The following is a description of a gene set: Genes up-regulated in CD4 T cells over-expressing FOXP3 and PPARg1 isoform of PPARG: GW1929 versus pioglitazone. studied in species Homo sapiens Pioglitazone treatment of CD4+FoxP3- T cells transduced with Pparg and Foxp3 up-regulated a set of genes whose products have been implicated in lipid metabolism pathways. To verify the specificity of this treatment, we performed microarray analysis on Foxp3+Pparg1-transduced CD4+FoxP3- T cells after treatment with other PPARg agonists such as Rosiglitazone (TZD) and GW1929 (non-TZD). Human Gene Set: GSE37534_GW1929_VS_PIOGLITAZONE_TREATED_CD4_TCELL_PPARG1_FOXP3_TRANSDUCED_UP from publication Cipolletta D, Feuerer M, Li A, Kamei N, Lee J, Shoelson SE, Benoist C, Mathis D (PMID 22722857), and this is the list of marker genes: OASL, RSAD2, COL4A1 (collagen type IV alpha 1 chain), SMR3A, FAM111A, TENT4A, TMEM106C, SFI1, IFITM1, AHSA1, ISG15, ZNF205, CAPN3, SPSB1, NMB, TRIM21, FOLH1B, FGF23, FOLH1, NUCKS1, KCNJ9, NEUROG1, TMSB10, OAS3, NUAK1, LILRB4, CDX1, MAPK11, CCN1, ITSN1, HLA-B, NSUN6, CASKIN2, MMP25, HSPB1, BST2, GMPR, ZNF212, IFI35, IFI27, OLFML1, MT1H, IBSP, HKDC1, GRP (NCBI Gene Id 2922), EPX, PCSK1 (proprotein convertase subtilisin/kexin type 1), ZNF273, CEACAM5, TYMP, CYP21A2, CCL22, HOXA3, HERC5, DNAJC4, ABTB2, SSTR3, SEMA4A, PPP2R2A, BTN3A1, APOBEC3G, CEACAM4, HRC, OCA2, H3-3B, SIK2, KLHL24, NRCAM, RPL18, GTF3C5, MX2, NUDT1, ID1, HBZ, ACKR1, LINC00623, ITGB7, PBX2, PER3, PTPRS (protein tyrosine phosphatase receptor type S), ABCC3, SNHG32, MGST2, MAP1LC3C, PTPRA, DTYMK, COPG1, SELL, MMP15, QTRT1, PDAP1, CEACAM1, MAN1B1, SLC7A7, LIME1, TNFSF12, ACAN, CDKN2A, TXNIP, ZNF74, FARP2, MT1M, MAGEA8, MIA3 (MIA SH3 domain ER export factor 3), ISG20, H2BC4, TCL1A, SLC26A1, CD86, DPYS, CDK18, OAS1, HTRA1, RBPJL, CYP26A1, SLC39A2, CASP1, ZSCAN12 (NCBI Gene Id 9753), MYH4, DUSP13B, FAM53B, APOL2, DPF1, PSMB9, APLP2, STX11, KIF16B, CRLF2, IGFLR1, OVOL3, GPA33, A1CF, SHFL, PRR4, GABRB1, LHB, PRDM16, TRMT61A, BAG1, ZNF428, OXA1L, ADAP1, FOXH1, LAGE3P1 (NCBI Gene Id 650244), TOMM40, S1PR1, EP400, TRIM14, OSGEPL1, MRPL17, TDRD7, EOLA2-DT, SCGB2A2, MMP14, SIRT3, CHRNB1, IFIT2, NLRP2, MFAP2, CDK5RAP3, TLR3, RPL26L1, BCCIP, CCNJL, CHD4, INPP4A, CRY2, PKD1P1, GPX1, IFITM3, C1QA, GABRB2, HOXA7, SPRR1A, MAN2A2, PSMB10, HLA-F, SMPD2 (sphingomyelin phosphodiesterase 2), SAA4, COX7A2L, GTF2H2B, SDHAP1, TENT5A, PLCB2, CCDC71, FXYD6 (FXYD domain containing ion transport regulator 6), CNP, TBX4, CASR, HEY2, GPR173, MTCH1, IFITM2, IDH2, CYP4F2, SLC25A37, CDC20, BBS9